Given this list of marker genes Otc (ornithine transcarbamylase), Ass1, Nmral1, Slc25a2, Arg1, Arg2, here is a description of the gene set: part of: Metabolism of amino acids and derivatives This event has been computationally inferred from an event that has been demonstrated in another species.<p>The inference is based on the homology mapping from PANTHER. Briefly, reactions for which all involved PhysicalEntities (in input, output and catalyst) have a mapped orthologue/paralogue (for complexes at least 75% of components must have a mapping) are inferred to the other species. Reactome Pathway: Urea cycle studied in species Mus musculus electronically inferred by orthology from the curated human pathway